Given this list of marker genes DNAAF10 (NCBI Gene Id 116143), FBXL16, TNF, ZNF385D, TMLHE, TMEM126A, RND2, RAB35, TULP2, PYHIN1, TTC33, ZNF414, SEPTIN3, RNASET2, UGGT1, SEMA6A, TK1, SPATS2L, TRIM36, SAMSN1, VENTXP1, RNF19A, ARHGAP42, SPATC1, RPN1, SNX3 (sorting nexin 3), TOR1AIP1, THBS2, PTPRT, ZIC1, SEC24D, IL13RA2, TMCO5A, SHB, UBL7, TFF2, THBD, THRB, TMEM208 (NCBI Gene Id 29100), WDR33, STK25, ZNF579 (NCBI Gene Id 163033), RPL3L, SPATA22, TPI1, SEMA4A, TRAPPC6B (trafficking protein particle complex subunit 6B), PSMA6, TINF2, PXDNL, SLC25A46, TUSC2, USP43, TTL, TLCD1, GFUS, STK16, SEC11A, PSRC1, RTN4, SPCS2, YPEL5, KATNB1, ST7-AS1, RANGRF, TEX11, GET1, TLX3, TBX3, TMEM63B, S100A16, ZFP69B, SPATA7, RNF214, SGO2, RBM28, TLN2, STC2, SOX2-OT, RHBDF2, TIMM17A, TBCCD1, ZNF394, PVR, TMEM158, ZSCAN9, UTP11, SCEL, SLC43A2 (solute carrier family 43 member 2), SLC26A11, ZNF34, NECTIN4, SLC22A1, PUSL1 (pseudouridine synthase like 1), ZDHHC8BP, SPATA12, PTPN18, RHOC, RASD1, TMEM125, SLC4A2, ZPBP2, RGL3, ROBO2, SLC4A9, RPE65, UBE4B, TDRD7, TRPM6, S1PR2, RAP2B, RSPH10B2 (NCBI Gene Id 730303), UBA6 (ubiquitin like modifier activating enzyme 6), ZSCAN29, TRABD, TIMM23B, ZNF142, SLC9A8, RTP1, TLR4, S100P, SLC9A5, SLC43A3, UBE2D1, YIPF2, RANBP9, TP63, SPATA2, TRAK1, ROCK1, UTS2B, RENBP (NCBI Gene Id 5973), SNAP91, SNAI3, SLC25A3, TIFAB, SAP30BP, SCAMP5, ZNRF2, SCGB3A2, WDHD1, TGM6, RRM1, TTTY13, TIMP1, LINC01121, SERPINA9, TP53I13, ZNF557, UNC13D, PSPN, SRL, TCP10L3, UBL3, TOMM22, TTC7A, ZCCHC13, HACD4, RPS6KB2, RUSC1, PSMG2, TRIM16, PSMA2, RNF10, TLL2, RBPMS, RTP3, SLC16A11, SEC23B, SLC22A18, REM2, SMAD1 (NCBI Gene Id 4086), WNT9B, VSTM1, PYGL, RAB2B, SAGE1, DENND2B, SPACA7, SOX11, TUBB4B, TRIML1, SCNN1G (sodium channel epithelial 1 subunit gamma), ZNF341, VAMP3, TPMT, TRIP12, SUSD1, ZAN, TNFAIP3, SEC61B, TP53INP2, RAD21L1, ROPN1B, UBE2U, UBA3, VPS35, UBE2J1, TBC1D4, SERHL2 (serine hydrolase like 2), here is a description of the gene set: Gene expression profiles of subsets of CD4+ T cells according to their expression of FoxP3 and CD45RA were compared. FoxP3 is a key transcription factor for the development and function of natural CD4+ regulatory T cells (Tregs). Here we show that human FoxP3+CD4+ T cells are composed of three phenotypically and functionally distinct subpopulations: CD45RA+FoxP3low resting Tregs (rTregs) and CD45RA-FoxP3high activated Tregs (aTregs), both of which are suppressive in vitro, and cytokine-secreting CD45RA-FoxP3low non-suppressive T cells. The proportion of the three subpopulations characteristically altered in cord blood, aged individuals, and patients with immunological diseases. Terminally differentiated aTregs rapidly die while rTregs proliferate and convert into aTregs in vitro and in vivo as shown by the transfer of rTregs into NOD-scid-common gamma-chain-knockout mice and by TCR sequence-based T cell clonotype tracing in peripheral blood of normal individuals. Taken together, the dissection of FoxP3+ cells into subsets enables one to analyze Treg differentiation dynamics and interactions in normal and disease states, and to control immune responses through manipulating particular FoxP3+ subpopulations. Human Gene Set: GSE15659_NAIVE_CD4_TCELL_VS_NONSUPPRESSIVE_TCELL_DN Genes down-regulated in comparison of naive CD4 T cells versus non-suppressive T cells. from publication Miyara M, Yoshioka Y, Kitoh A, Shima T, Wing K, Niwa A, Parizot C, Taflin C, Heike T, Valeyre D, Mathian A, Nakahata T, Yamaguchi T, Nomura T, Ono M, Amoura Z, Gorochov G, Sakaguchi S (PMID 19464196) species: Homo sapiens